The following is a description of a gene set: studied in species Homo sapiens Reactome Pathway: Transport of nucleosides and free purine and pyrimidine bases across the plasma membrane part of: Transport of vitamins, nucleosides, and related molecules Two families of transport proteins mediate the movement of nucleosides and free purine and pyrimidine bases across the plasma membrane. Equilibrative nucleoside transporters allow the movement of these molecules along concentration gradients into or out of cells; concentrative nucleoside transporters actively transport nucleosides into cells by coupling their transport to the inward movement of sodium ions.<P>Of the four human equilibrative nucleoside transporters, two are well characterized. SLC29A1 (solute carrier family 29 (nucleoside transporters), member 1) mediates the transport of nucleosides across the plasma membrane. SLC29A2 (solute carrier family 29 (nucleoside transporters), member 2) mediates the transport of both nucleosides and free bases. Transporter specificities were determined by expressing cloned human genes in Xenopus oocytes or in mammalian cultured cell lines whose own nucleotide transporters had been disrupted by mutation. These studies establish that the transport processes are specific and saturable, and that the multiple nucleotides and bases compete for a single binding site on each transporter. Some features of SLC29A2 specificity are complex. For example, in the Xenopus oocyte system, radiolabeled uracil and adenine are taken up, and an excess of either molecule inhibits uptake of radiolabeled hypoxanthine, while in the cultured mammalian cell system, neither adenine nor uracil can inhibit uptake of radiolabeled uridine. If these results reflect ENT2 function in vivo, they indicate that the net movement of a nucleoside or base across the cell membrane is determined not only by its own concentrations in the extracellular space and the cytosol, but also by the concentrations of the other nucleosides and bases competing for access to the transporter.<P>The human genome encodes three concentrative transporters, SLC28A1, 2, and 3 (solute carrier family 28 (sodium-coupled nucleoside transporter), member 1, 2, and 3). All three genes have been cloned, and expression of the human proteins in Xenopus oocytes has allowed their transport properties to be determined. SLC28A1 mediates the uptake of pyrimidine nucleosides and adenosine; SLC28A2 the uptake of purine nucleosides and uridine; and SLC28A3 the uptake of purine and pyrimidine nucleosides. Amino acid sequence motifs that determine the specificities of these transporters have been identified in studies of chimeric and mutant proteins. SLC28A3 protein co-transports two sodium ions per nucleoside; SLC28A1 and 2 transport one sodium per nucleoside.<P>Physiological roles for nucleoside and base transport include provision of nucleosides to cells with little capacity to synthesize these molecules de novo, and regulation of extracellular levels of adenosine, which is released from muscle during intense exercise and has signaling properties. In kidney and intestinal epithelia, the combination of apically localized CNT transporters and basolaterally localized ENT transporters provides a mechanism for net transport of nucleosides. These transporters also mediate the uptake of nucleoside analogs used clinically as anti-viral and anti-tumor drugs.<P>Orthologs of human concentrative and equilibrative transporter proteins have been identified in many eukaryotes, but functional studies of transporters even from organisms closely related to humans (e.g. rat, Gerstin et al. 2002) have revealed differences in substrate specificities. Prediction of drug uptake and other functions of these molecules by human - model organism orthology is thus risky., and this is the list of marker genes: SLC28A2, SLC28A3, SLC25A4, SLC25A5, SLC28A1, SLC29A1, SLC29A4, SLC25A6, ARL2BP, SLC29A3, SLC29A2, ARL2